The following is a description of a gene set: Mouse Gene Set: chr11B5 species: Mus musculus, and this is the list of marker genes: Gm22947, Srr, Gm12339, Gm11190, Gm11207, Ksr1, Gm22772, Ccdc92b, Slc13a2os, 4930527B05Rik, Gm10277, Mir212, Cpd, Dph1, Glod4, Rilp, Rab11fip4os1, Gm12571, Omg, Mir6926, Mrm3, Nsrp1, D11Bhm181e, Nf1, Ssh2, Gm11418, Or3a1b, 5730455P16Rik, Cryba1, Gm11191, Adap2, Coro6, Ovca2, Or1a5-ps1, Serpinf2, Mnt, Abr, Trarg1, Sarm1, Rpl23a, Rab11fip4os2, Wsb1, Hic1, Gm24454, Mettl16, Asic2, Gm12340, 9130204K15Rik, Or1a1, Gm11205, Gm11419, Vps53, Mir423, Gm11197, 1700016P03Rik, Or1p1b (NCBI Gene Id 257920), Gm22733, Serpinf1, Rab34, Psmd11, Snord4a, Or3a1c, Mir193a, Gm24887, Suz12, Gm17235, Cluh, Or1p1c, Ankrd13b, Slc6a4, Tlcd2, Eral1, Gm12332, Gm10392, Gm12337, Rhbdl3, Rhot1, Tmem98, Lyrm9, Mir3971, C030013C21Rik, Mir22hg, Gm25867, Or3a1, Or1a7-ps1, Nufip2, Gm12343, Spaca3, Gm24989, Evi2, Gm11201, Nxn, Scarf1, Or1p1, Dbil5, Spag5, Rpl36-ps2, Mir132, Sdf2, 4931413K12Rik, Blmh, Sgsm2, Or3a1d, Gemin4, Or1p4-ps1, Myo1c, Pigs, Or1a1b, Gm24211, 4930507D10Rik, Sebox, Gm12344, Ywhae, Mir22, Foxn1, Smyd4 (SET and MYND domain containing 4), Tsr1, AU040972, Nek8, Slc46a1, Gm3948, Ccnq, Gm11416, Traf4, Doc2b, Flot2, Tnfaip1, Snord42b, Slc43a2, Gm12341 (NCBI Gene Id 102632956), Gm45606, Mir7653, Rap1gap2, Poldip2, Snord42a, Phf12, Gm12346, Mir365-2, Tlcd1, Gm11196, Myo18a, Zfp207, Gm12335, Taok1, Trp53i13, Bhlha9, Rph3al, Fam222b, Rpa1, Gm11203, Adap2os, Bltp2, Rflnb, Timm22, Or1d2 (olfactory receptor family 1 subfamily D member 2), Mir144, Rps12-ps19 (NCBI Gene Id 638567), Tmem199, Gm12734, Supt6, Gm12333, Crk, Gm12338, 5530401A14Rik, Vtn, Gm12733, Dhrs13, Cdk5r1, Gm23219, Gosr1, Evi2b, Sez6, Nlk, Unc119, Or1a6-ps1, Lgals9, Proca1, Pipox, Gm11198, Utp6, Tlcd3a, Slc13a2, Liat1, Tmem97, Crlf3, Rskr, Wdr81, Dhrs13os, Gm9964, Pitpna, Prpf8, 1700071K01Rik, Inpp5k, Pafah1b1, Git1, Efcab5, Ift20, Evi2a, Rab11fip4, Atad5, Snord91a, Gm12345, Myo1d, Rtn4rl1, Smg6, Rnf135, Or3a15-ps1, Nos2, Abhd15, Tmigd1, Aldoc, Gm11200, Gm23293, Tefm